The following is a description of a gene set: species: Homo sapiens APC/C:Cdc20 is first activated at the prometaphase/metaphase transition through phosphorylation of core subunits of the APC/C by mitotic kinases as well as recruitment of the APC/C activator protein Cdc20. APC/C:Cdc20 promotes the multiubiquitination and ordered degradation of Cyclin A and Nek2 degradation in prometaphase followed by Cyclin B and securin in metaphase (Reviewed in Castro et al., 2005). Reactome Pathway: Activation of APC/C and APC/C:Cdc20 mediated degradation of mitotic proteins part of: APC/C-mediated degradation of cell cycle proteins, and this is the list of marker genes: ANAPC11, CDC26, PSMC1, PSMD7 (NCBI Gene Id 5713), CCNA2, SEM1, PSMC2, UBE2D1, PSMA2, PSMC4, PTTG1, PSMA1, PSMD13, ANAPC5, CDC27, ANAPC2, MAD2L1, PSMD11, PSMD14, CDC20 (NCBI Gene Id 991), PSMD12, PLK1, PSMB7, PSMD8, PSMD1, PSMB6, CDC23, UBB, PSMD3, PSMB3, PSMA4, ANAPC7, PSMB2, ADRM1, PSMA5, ANAPC10, ANAPC15, PSMA7, BUB1B, PSMD2, NEK2, PSMD6, PSMB1, RPS27A, PSMB4, UBE2S, CCNA1, CDC16, PSMC3, PSMC6, CCNB1, ANAPC4 (anaphase promoting complex subunit 4), PSMA6, UBA52, CDK1, UBE2E1, UBC, PSMC5, ANAPC1, PSMA3, UBE2C, ANAPC16, BUB3 (NCBI Gene Id 9184), PSMB5